Given this list of marker genes CDCA5, CIB2, PLK4, HOXB7, ZNF200 (zinc finger protein 200), HOXA5, PREX1, GMNN, KIF23, PHACTR2, GDAP1, MYH11, FOXK2, NECTIN1, PLK1, EPHB4, SFTPB, CENPE, PTTG1, ZIC2, SLF1, ROBO3, RUSC1, NUP205, SCAP, LAMB1, CDCA7L, GON4L, SRPK1 (SRSF protein kinase 1), HERC2, ARHGAP11A, NOL6, H2AX, NUF2 (NUF2 component of NDC80 kinetochore complex), KIF11, ACD, SMC2, USHBP1 (NCBI Gene Id 83878), TPX2, AFAP1, ILF3, VAV2, RPUSD1, BAIAP2L1, TJP1, EFCAB2, SNRPA, PTCD1, ORC1, SEMA3F, ABI2, DLEU2, TRIP13, GRAMD1A, CABIN1, SSR4P1, CDC20 (cell division cycle 20), ALDH7A1, NRM, CACNB3, E2F1, ARHGEF16 (Rho guanine nucleotide exchange factor 16), RAB6B, NDC80, MBNL3, IGFBP6, ARFIP2, PADI3, PMCHL1, PPT2, TNRC6A (NCBI Gene Id 92763), AURKA, FGG, DDX11, NCAPH, EYA2, DVL2, TINCR, ZNF74, RAD51D, JMJD4, ATP1A3, CDC45, OGDHL, F5, FER1L4, HEATR6 (HEAT repeat containing 6), TBC1D1, SALL2, FOXM1, HTR2A, TRAP1, GRAMD1B, CDC25B, RFPL3S, THBS3, ANKEF1, MSLN, SOCS7, MYBL2, BUB1B, EFNA1, MRPS26, NOL12, DNAH6, ZNF184, BCAS3, DONSON, MBNL2, IGSF3, GPSM2, TRIP6, NT5M, DYNC2I2, BYSL, SAC3D1, ZNF432, CENPF, PYGO2, ASF1B, NCAPD2, here is a description of the gene set: species: Homo sapiens Human Gene Set: MODULE_397 Genes in the cancer module 397.